Given this list of marker genes H2ac11, H4c11, Pparg, H4c4, Hdac3, H3c2, H2bc9, H2ac10, H2ac19, H3c7 (NCBI Gene Id 260423), H3c8, H3c6, H2bc8, H4c3, H2ac15, H2bc12, H3f3a, H2ac24, H4c1, H3c10, H2ac1, H4c6, H4c8, H2bc11, H4c12, H2ac20, H2ac7, H2ac12, Tbl1x, H3c1, H4c9, H3c11, H2bc27, H2ac4, Ncor2, H2ac23, H2ac8, H3c13, H3c3, Gps2, H2bc13, H4c17 (NCBI Gene Id 100041230), H3c4, H2bc15, H2bc22, H4c14, H2bc7, H3c15, H2ac22, H2bc3, H2ac6, H2ac13, H2az2, H4c18, H4c2, H2bc1, H2ax, here is a description of the gene set: part of: Epigenetic regulation of gene expression by MLL3 and MLL4 complexes electronically inferred by orthology from the curated human pathway This event has been computationally inferred from an event that has been demonstrated in another species.<p>The inference is based on the homology mapping from PANTHER. Briefly, reactions for which all involved PhysicalEntities (in input, output and catalyst) have a mapped orthologue/paralogue (for complexes at least 75% of components must have a mapping) are inferred to the other species. studied in species Mus musculus Reactome Pathway: Epigenetic regulation of adipogenesis genes by MLL3 and MLL4 complexes